The following is a description of a gene set: Human Gene Set: GOBP_REGULATION_OF_MULTICELLULAR_ORGANISM_GROWTH studied in species Homo sapiens Any process that modulates the frequency, rate or extent of growth of the body of an organism so that it reaches its usual body size., and this is the list of marker genes: BCL2, VIL1, PTCH1, PRLH, GHRH, GPR21, BBS2, SUV39H1, PPIB, ATRN, HTRA2, FTO, HMGA2, MFSD2A, POU3F2, ADRB1, SOD1, CREB1, GPAT4, PLS1, NPY1R, HSF1 (NCBI Gene Id 642255), GAMT, CSF1, FOXS1, GHRHR, IGF2, FOSL2, CHD7, HDAC3, CACNA2D2, ZMPSTE24, GPAM, RAI1, ADRB2, AFG3L2, ATP8A2, GHSR, STC2, SOCS2, MKKS, PLAC8, PEX5, PIK3CA, NIPBL, DRD2, STAT3, GNAS, GH1, MBD5, EZR, GDF5, BBS4 (Bardet-Biedl syndrome 4), NPPC, SMO, ADRB3, SPTBN4, STAT5B, SGPL1, GHRL, GDF15, DIO3, GHR, APP, STAT5A, FXN, LGMN, SLC6A3